The following is a description of a gene set: Mouse Gene Set: GOBP_POSITIVE_REGULATION_OF_ANOIKIS Any process that activates or increases the frequency, rate or extent of anoikis. species: Mus musculus, and this is the list of marker genes: Chek2, Cryba1, Tle5, Mybbp1a, Brms1, Ptrh2, Sik1